Given this list of marker genes Abr, Arhgef38, Gng8, Mcf2, Arhgef7, Rock2, Gng4, Rhoa, Obscn, Itsn1, Vav1, Arhgef10l, Fgd3, Gng11, Gngt2, Adra1a (adrenergic receptor, alpha 1a), Gng10, Rasgrf2, Gng3, Vav3, Arhgef39, Fgd1, Arhgef2 (Rho/Rac guanine nucleotide exchange factor 2), Adra1d, Gng5, Net1, Trio, Arhgef16, Plekhg5, Gnb2, Rock1, Gng13, Gnb4, Gnb3, Btk, Arhgef25, Sos1, Gna12, Ect2, Gngt1, Sos2, Arhgef17 (Rho guanine nucleotide exchange factor 17), Fgd2, Gng2, Gnb1, Akap13, Arhgef33, Mcf2l, Gna13, Tiam2, Plxnb1, Arhgef19, Fgd4, Arhgef26, Kalrn, Adra1b, Arhgef10, Arhgef1, Arhgef5, Arhgef18 (NCBI Gene Id 319493), Arhgef3, Rhoc, Gng7, Plekhg2, Prex1, Arhgef15, Arhgef9, Rhob, Tbxa2r (thromboxane A2 receptor), Vav2, Arhgef6, Ngef, Arhgef11, Gnb5, Gng12, Arhgef37, Arhgef12, here is a description of the gene set: G alpha (12/13) signalling events Mouse Gene Set: REACTOME_G_ALPHA_12_13_SIGNALLING_EVENTS species: Mus musculus